Given this list of marker genes Cav1, Th, Tpo, Tph1, Duoxa1, Dio1, Ddc, Dio2, Dbh, Aanat, Iyd, Duoxa2, Cga, Duox1, Pnmt, here is a description of the gene set: part of: Metabolism of amino acids and derivatives Reactome Pathway: Metabolism of amine-derived hormones electronically inferred by orthology from the curated human pathway This event has been computationally inferred from an event that has been demonstrated in another species.<p>The inference is based on the homology mapping from PANTHER. Briefly, reactions for which all involved PhysicalEntities (in input, output and catalyst) have a mapped orthologue/paralogue (for complexes at least 75% of components must have a mapping) are inferred to the other species. studied in species Mus musculus